Given this list of marker genes MUS81, BAZ1A, BAZ1B, SLX4, INO80C, EME2, SYCP1, TOP2A, SMC4, TIMELESS, TEX12, GINS4, MCM3, RPA1, FIRRE, RBBP7, SYCE3, KMT2E, LRIF1, ORC3, KAT5, POLD3, JUN, SIRT7, ACTR6, NOL6, RGS12, SMARCAL1 (NCBI Gene Id 50485), FAM9B, ARID4A, BCAS2 (BCAS2 pre-mRNA processing factor), H2AZ1, SAP130, ING1 (inhibitor of growth family member 1, NCBI Gene Id 3621), SHOC1, TRRAP, NCAPH2, PRIM1, TIPIN, SMC1A, MEI4, SYCE2 (synaptonemal complex central element protein 2), ARID4B, ORC4, AGO3, RPA4, TET1, ANP32E (acidic nuclear phosphoprotein 32 family member E), RBBP4, MLH3, P3H4, ING2, RPA3, PLRG1, HUS1, LRPPRC, HORMAD1, BRMS1L, FAM9C, CDC45, CFDP1, BRCA2, HMGA2, EME1, RAD9B, POLE3, SPO11, INO80E, SMC1B, H3-4, GINS3, POLD1, SETD5, INO80, SYCE1, SYCP2, ORC1 (NCBI Gene Id 4998), MCM7, TERF2IP, RNF212B, MCM5, MCRS1, CPSF6, TFPT, POLA1, GINS2, DNMT3L, POLD4, BRD8, HDAC8, HORMAD2, C14orf39, RUVBL1, SYCP2L, POLA2, MCM6, ETAA1, TRIM24, UBE2I, ORC2, RNF212, PSMC3IP, CHMP1A, BRMS1, ACTR5, ERCC5, MMS22L, SLC5A8, SAP30L, ORC6, NFRKB, RAD21, RAD51, MSH4, TONSL, GINS1 (NCBI Gene Id 9837), NUFIP1, SMARCAD1, KASH5, H3-3B, E2F1, IK, NIFK, ACTR8, SMARCA5, SUV39H1, PARP1, SIN3A, REC8, TEX11, SMCHD1, PHF12, PCNA, ZNHIT1, STAG3, POLD2, UCHL5, H3-3A, HELB, MCM10, NCAPG, RAD9A, ACTL6A, CARM1, INCENP, RRS1, HDAC2, ING3, DMAP1, RCC1, INO80D, SLX1A, SMC3, MLH1, RAD50, MACROH2A2, SAP30, DHX9, DMC1, NCAPG2, CDX2, POLE2, MORF4L1, EXOSC9, HUS1B, SUDS3, LRWD1, PRIM2, SETX, HSPA2, SINHCAF, SWI5, BRD4, YY1, CCNB1IP1, PLK1 (polo like kinase 1), SMC2, NCAPH, RPA2, HNRNPU, HDAC1, RSPH1, BRCA1, SRCAP, FKBP6, RUVBL2, BLM, SLX1B, MCM2, SYCE1L, TTN (titin), TUBG1, ATRX, MCM4, SPIDR, RAD1, OGT, TOPBP1, XPA, BIRC5, ZRANB3 (NCBI Gene Id 84083), PINX1, INO80B, SFR1, SUN2, MACROH2A1, POLE (NCBI Gene Id 80252), CSNK2A1, SIN3B, ZMIZ2, CHD1, YY1AP1, IHO1, FIGNL1, SYCP3, TREX1 (NCBI Gene Id 82474), WDHD1, SYN1, CDC5L, NCAPD2, ADD3, CHEK1, SMARCE1, NCAPD3, TOP1, H2AX, CHRAC1, NEK2, FAM9A, PRPF19, CAMSAP3, ORC5, TARDBP, EP400, KIFAP3, POLE4, PBRM1, SMARCB1, here is a description of the gene set: Human Gene Set: GOCC_NUCLEAR_CHROMOSOME studied in species Homo sapiens A chromosome that encodes the nuclear genome and is found in the nucleus of a eukaryotic cell during the cell cycle phases when the nucleus is intact.